The following is a description of a gene set: Human Gene Set: GSE17186_CD21LOW_VS_CD21HIGH_TRANSITIONAL_BCELL_CORD_BLOOD_UP from publication Suryani S, Fulcher DA, Santner-Nanan B, Nanan R, Wong M, Shaw PJ, Gibson J, Williams A, Tangye SG (PMID 19965666) species: Homo sapiens Genes up-regulated in transitional B lymphocytes from cord blood: CR2 low versus CR2 high. Goals/objectives: to identify various gene expression in B cell subsets derived from human PBMC and cord blood, and this is the list of marker genes: ALMS1, CDC25A, CREB3L2, PTOV1, IFITM2, TRIP10, ADAP2, PLBD2, TAP2, CD80, CLINT1, HGFAC, HS6ST1, HDAC6, SPRED2, STX11, DIP2A, FBXO10, SUMF1, FRMD4A, CLDND1, SCARB2, APP, SNAP23, TUBB2B, USP22, TTC8, CITED2, ZNF623, GLS, EIF4A1, RAB1A, MKNK1, ITGAV, STX12, CEBPA (CCAAT enhancer binding protein alpha), ALDOC, ALS2CL, ACO1, CSGALNACT2, VPS37C, AGFG2, HLA-DRB1, HSP90B1, TSPAN4, KIFAP3, VAV3, STARD3NL, ZNF710, PREX1, MYOM1, HM13, NDST2, RAP2A, KCNK12, FBXO6, LPIN1, HAUS8, DHRS1, IL13RA1, HEATR5A, POGLUT3, PIK3R5, DKK3, PLEKHB2, SLC6A13, NBDY, ARRB1, PKIB, FAM91A1, DYNC1LI1, DPY19L4 (dpy-19 like 4), ITM2B, SSX2IP, SRSF9, TUSC1, PIGN, KYNU, SDCBP, GNB2, HK3, ATP8B2, DHRS13, SLC39A11 (solute carrier family 39 member 11), COP1, SLC33A1, DNAJC3, NBEAL2, JPT2, LGALS3BP, DPYSL2, SCAMP2, SANBR, AKR7A2, TAF6L, GALNT7, RAB19, PRCP, RNPEP, CA9, ACACA, CD99L2, ENPP4, CD36, SLC12A9, MYO9A, SMPDL3B, FGD1, CERS6, COPS7A, LRPAP1, ELMO2, KANK3, ELAC2, ABL1, CDK5RAP3, CASP7, FAM98C, AGPAT3, GABBR1, SURF4, C1orf54, PDCD6IP, COA5, ABCA3, TPCN2, DGLUCY, ISOC1, TNFRSF11A, RAC1, RAB11FIP1, CRTAP, SPINT1, RCBTB2, H1-0, PADI2, B4GALT4, SYNRG, RAB29, NUCB1, TYK2, VILL, PRPF19, ACOT7, PTBP2, EXTL3, MAPK13 (mitogen-activated protein kinase 13), GSAP, IL6ST, CFAP410, ARPC1B (NCBI Gene Id 10095), PROSER2, LRRC40, CRYBG3, SASH1, FAM89B, PRR13, PIP4K2A, GFPT1, RAD54L, C11orf54, EXOC3L4, CPTP, RAB10, SRGAP2, GPR137, VAMP3, NDUFA9, EBP, XPNPEP1, PLEKHO2, KDM2B, DCTN5, ARID4A, PDGFB, ARHGEF39, ATP6V1D, GNAQ, IPCEF1, TLR2, CYP4V2, SLC36A4, GOLIM4, NDUFA8, IER3IP1, TOX4, SEPTIN9, SLC25A26, MGAT4B, PSME2, EXTL2, GLCE, SIPA1L3, RNASET2, BCAS3, PPFIA4, WDR13, SNX1, CSTB, CTNND1